Given this list of marker genes APOC1, APOC3, PNLIPRP1, LIPC, PNLIPRP3 (pancreatic lipase related protein 3), ABCA5, PLA2G3, ABCG1, APOA4, PLTP, LPL, LIPG, PNLIPRP2, CETP, APOA2, APOM, APOA1, APOE, SCARB1, PNLIP, LCAT, here is a description of the gene set: Human Gene Set: GOBP_HIGH_DENSITY_LIPOPROTEIN_PARTICLE_REMODELING studied in species Homo sapiens The acquisition, loss or modification of a protein or lipid within a high-density lipoprotein particle, including the hydrolysis of triglyceride by hepatic lipase, with the subsequent loss of free fatty acid, and the transfer of cholesterol esters from LDL to a triglyceride-rich lipoprotein particle by cholesteryl ester transfer protein (CETP), with the simultaneous transfer of triglyceride to LDL.